Given this list of marker genes TIAM2, FOS, SETX, SPRY2, SAMSN1, TMPRSS11D, CCN1, BNIP3, DNAJC5, LNPEP, HBEGF, SSX2IP, TOMM40, IRX1, CXCL12, DMP1, ARX, FOXG1, VWA1, VHL, ARL6IP5, DUSP3, ENO1, TRAF6, S100A13, MMP8 (NCBI Gene Id 4317), MINK1, FOXO3, PGF, RPS6KA5, DAP (NCBI Gene Id 1611), PPP1R9B, ZFP36, CSRNP1, PRDX5 (NCBI Gene Id 25824), EIF1B, PRPF19 (NCBI Gene Id 27339), ENO2, LHX9, GZF1, MYH9, SIK3, NPEPPS, LXN, KLHL2, FST, INSIG2, CPD, ERRFI1, NFKBIA, IFNA5, MERTK, KLF10, PIM3 (Pim-3 proto-oncogene, serine/threonine kinase), SH3BP4, TK2, IL18, ATP7A, PFKFB3, SLC2A1, GAPDH, ME2, POLR2D, POU6F1, PNRC1, TRAF3IP2, MT1F, ADM, ANKRD1, SKIL, CMC4, LRP5, CAVIN3, GPRC5C, BHLHE40, SHB, CCN2, LMO7, SOAT1, TGIF1, GYS1, HILPDA (NCBI Gene Id 92496), CAV1, NOCT, ACER3, ZNF143, SELENBP1, PSMC4, MMP3, DUSP14, HIGD1A, LLGL1, TCIM, CCSAP, KLF4, ACAP2, PPL (periplakin), CAPN1, GBE1, GADD45G, CDC42EP3, KIF5A, EDN1, PDLIM4, CACNA1H, DEPP1, SGK1, RBPJL, NPTX1, VEGFA, here is a description of the gene set: Human Gene Set: GROSS_HYPOXIA_VIA_HIF1A_DN The ternary complex factor Net/Elk3 is downregulated in hypoxia and participates in the induction by hypoxia of several genes, including c-fos, vascular endothelial growth factor and egr-1. However, the global role of Net in hypoxia remains to be elucidated. We have identified, in a large-scale analysis of RNA expression using microarrays, more than genes that are regulated by Net in hypoxia. In order to gain insights into the role of Net in hypoxia, we have analysed in parallel the genes regulated by HIF-1alpha, the classical factor involved in the response to hypoxia. We identified about genes that are regulated by HIF-1alpha in hypoxia. Surprisingly, when we compare the genes induced by hypoxia that require either Net or HIF-1alpha, the majority are the same (75%), suggesting that the functions of both factors are closely linked. Interestingly, in hypoxia, Net regulates the expression of several genes known to control HIF-1alpha stability, including PHD2, PHD3 and Siah2, suggesting that Net regulates the stability of HIF-1alpha. We found that inhibition of Net by RNAi leads to decreased HIF-1alpha expression at the protein level in hypoxia. These results indicate that Net participates in the transcriptional response to hypoxia by regulation of HIF-1alpha protein stability. from publication Gross C, Dubois-Pot H, Wasylyk B (PMID 17704799) studied in species Mus musculus Genes down-regulated in SEND cells (skin endothelium) at hypoxia after knockdown of HIF1A by RNAi.